The following is a description of a gene set: Wnt signaling in kidney disease Mouse Gene Set: WP_WNT_SIGNALING_IN_KIDNEY_DISEASE species: Mus musculus, and this is the list of marker genes: Wnt5b, Fzd4, Fzd1, Btrc, Fzd2, Wnt9b, Gsk3b, Kitl, Dvl2, Fzd7, Wnt2b, Wnt10a, Mapk8, Lrp5, Lrp4, Apc, Nlrp3, Wnt11, Wnt4, Ctnnb1, Fzd9, Dvl3, Mapk10 (mitogen-activated protein kinase 10), Wnt3a, Mapk9, Dvl1, Wnt7a, Wnt1, Wnt7b, Fzd3, Csnk1a1, Axin1, Wnt10b, Wnt6, Rhoa, Wnt16, Fzd8, Wnt2, Wnt3, Fzd6, Fzd5, Wnt5a, Invs